The following is a description of a gene set: The process whose specific outcome is the progression of a cranial ganglion over time, from its formation to the mature structure. Human Gene Set: GOBP_CRANIAL_GANGLION_DEVELOPMENT species: Homo sapiens, and this is the list of marker genes: NRP1, CTNNB1, SIX4, SIX1, NRP2